The following is a description of a gene set: Increased sensitivity to stimulation, excluding the special senses, which may refer to various modes of cutaneous sensibility including touch and thermal sensation without pain, as well as to pain. Hyperesthesia studied in species Homo sapiens Human Gene Set: HP_HYPERESTHESIA, and this is the list of marker genes: NF2, COL1A1, GALC, NALCN, HRAS, NTRK1, PSAP, ATL1, UNC80